The following is a description of a gene set: Genes predicted to be targets of miRBase v22 microRNA mmu_miR_381_5p in miRDB v6.0 with MirTarget v4 prediction scores > 80 (high confidence targets). Mouse Gene Set: MIR_381_5P species: Mus musculus from publication Chen Y, Wang X (PMID 31504780), and this is the list of marker genes: Mrpl21, Ptar1, Ralgapb, Ddn, Polr3d